Given this list of marker genes Noxred1, Oat, Dao, Prodh2, Prodh, Pycr1, Pycr3, Aldh4a1, Pycr2, Aldh18a1, here is a description of the gene set: species: Mus musculus Mouse Gene Set: GOBP_PROLINE_METABOLIC_PROCESS The chemical reactions and pathways involving proline (pyrrolidine-2-carboxylic acid), a chiral, cyclic, nonessential alpha-amino acid found in peptide linkage in proteins.